The following is a description of a gene set: Integrin cell surface interactions species: Homo sapiens Human Gene Set: REACTOME_INTEGRIN_CELL_SURFACE_INTERACTIONS, and this is the list of marker genes: ITGB3, COL6A6, JAM3, FBN1, FGA, COL23A1, COL2A1, ITGAM, COL6A1, COL5A3, COL7A1, SPP1, COL9A1, ITGB8, COL4A1, CDH1, VTN (NCBI Gene Id 7448), ITGAD, TNC, ITGA8, ITGA11, ICAM5, ITGAL, COL5A1, COL13A1, COL18A1, F11R, PECAM1, LUM, ITGA3, ITGB5, COL4A6, COL4A2, IBSP, ITGAX, COL8A1, ITGA5, ITGA6, ITGB1, ITGB7, COL4A4, COL9A2, ITGAV (NCBI Gene Id 7449), COL9A3, COL10A1, COL6A2, COL16A1, COL6A3, ICAM4, FGG, ITGB2, ITGA9, ICAM3, FGB, ICAM1, FN1, COL1A2, COL4A3, JAM2, COMP, BSG, COL6A5, THBS1, HSPG2, CD44, COL8A2, ITGA1, KDR, ITGA4, ITGB6, COL5A2, CD47, COL4A5, ITGA2B, VWF (NCBI Gene Id 7450), ITGAE, MADCAM1, AGRN, ITGA2, VCAM1, COL3A1, ITGA7, COL1A1, ITGA10, ICAM2